Given this list of marker genes KDM5A, LAMC2, EFL1, NOP10, FAM83H, CPLX1, AMBN, TERC, ITGA6, SUMO1, PEPD, P4HB, AMTN, TRMT10A (tRNA methyltransferase 10A), PWRN1, GJA1, WDR35, FGF3, TMEM165, TGFA, WHRN, CDH23, PTCH1, LONP1, ARSB, GNB2, AKT1, AGA, AARS1, IFT43, STX1A, ATRIP, HLA-DRB1, DNAJC21, CHD3, EIF4H, DNA2, IFT122, APC, ZNF469, PGM2L1, UROD, UBR1, SNORD115-1, ZMPSTE24, STIM1, CENPE, CRLF1, DSPP, KRT5, AXIN2, COL1A1, RAD21, DMP1, ERCC8, CLDN16, GTF2IRD1, NUP85, DEAF1, GP1BB, RECQL4, GREM2, SATB1, LRP4, MSX1, SOX9, USH1C, ORAI1, VAC14 (NCBI Gene Id 55697), SLC24A4, ADGRV1, RELT, RTEL1, RUNX2, TARS1, CCDC8, SHOC2, TINF2, LAMB3, IKBKG, GALNS (NCBI Gene Id 2588), ENPP1, SNRPN, GLB1, PLK4, FAM111A, FGFR1, METTL27, PAX9, IL17RA, COL7A1, CCR6, RREB1, PEX6, EDA, ALDH3A2, TRPS1, OFD1, CDH11, RNF113A, ACP4 (NCBI Gene Id 93650), PAX1, NELFA, USH2A, LMX1B, POLR1C, NUP133, JMJD1C, TRIP11, ALPL, USH1G, PKP1, TP63, CLDN1 (claudin 1), GTF2H5, IL17RC, SFRP4, ADNP, ATP6V1A, CARS1, NF1, COL5A1, WRAP53, ATR, ELANE, ZMYM2, SP7, SMARCD2, SCUBE3, IRX5, KIF7, CDH3, TGFB1, WNT10A, POLR1B, FAM20C, TMEM270, FERMT1, RFC2, MEGF8, SLC29A3, ATP6V1E1, HLA-DQB1, TCIRG1, TRPV3, SLC12A2 (NCBI Gene Id 6558), STAT3, SBDS, ASL, ROGDI, OCRL (OCRL inositol polyphosphate-5-phosphatase), GPR68, ANAPC1, CIB2, LAMA3, IFITM5, EDAR, VPS37D, PORCN, GTF2IRD2, KCNJ5, AMELX, SPARC, LRP6, BUD23, NEK1, ALMS1, DPH5, FGFR2, B3GALT6, RBM28, TBCE, P3H1, TERT, CTC1, TNFSF11, BMP1, NECTIN1, GRHL2 (NCBI Gene Id 79977), ABL1, IFT52, SGMS2 (sphingomyelin synthase 2), DLX3, ITGB6, FIG4, FLII, COL17A1, PPP1CB, SEC23A, DHCR7, DNAJC30, LTBP3, MYO7A, ATP6V0A2, PERP, PTCH2, PCGF2, DKC1, IRF5, NHP2, CLIP2, GTF2I, CREBBP, GTF2E2, KLK4, LETM1, NDUFB11, TSC1, SLF2, SNRPB, HERC2, COL1A2, TCOF1, MMP1, KRT14, POLR1D, TRAF3IP2, SLC10A7, ERCC3, LIFR, ARVCF, TRIM37, PGAP1 (post-GPI attachment to proteins inositol deacylase 1), TSC2, PDZD7, SLC19A1, SERPINH1, SERPINF1, COL3A1, PIK3C2A, SLC35A2, TBL2, AIRE, UBE3B, MAPRE2, ERCC6, COX4I2, FKBP6 (FKBP prolyl isomerase family member 6 (inactive)), TRAIP, RAI1 (NCBI Gene Id 6600), NECTIN4, MKRN3, CEP152 (centrosomal protein 152), UFD1, KRAS, PIGG, MMP13, RBBP8, COX7B, PCDH15, FLNA, OBSL1, BAZ1B, EP300, SEC24C (SEC24 homolog C, COPII coat complex component), NTRK1, NPM1, PLEC, PWAR1, TTC7A, KMT2D, PCNT, FAM20A, STX16, MPLKIP, GATA1, CTNND1 (catenin delta 1), GNAS, IQSEC2, PPP1R15B, NCF1, FGF23, SLC37A4, SMCHD1, PAK2, KCNJ2, MMP20, POLD3, UROS, CCN2, WDR19, DIAPH1, SMARCA2, FGFR3, FGF10, CLDN19, COMT, TYMS, RNU12, LIMK1, TBX1, CRTAP, IFNG, CTBP1, ENAM (enamelin), SUFU, HLA-DQA1, ITGB4, PDE4D, PPIB, PHEX, PARN, USB1, FKBP10, THOC6, CDH1, TNFRSF11A, CUL7, TMEM38B, VDR, SEC24D, CTSK, SRCAP, PTDSS1, RAP1B, GALNT3, EDARADD, CYP2R1, ODAPH, BMP4, NPAP1, SLC13A5, MED12, C12orf57, CAV1, FOSL2 (NCBI Gene Id 79579), COL5A2, ERCC1, CLCN7, ESPN, WNT10B, ERCC4, ELMO2, HECTD4, IL17F, CNNM4, FLNB, AP3B1, ERCC2, PEX1, SCNM1, NSD2, ELN, BRF1, WDR72, CYP27B1 (cytochrome P450 family 27 subfamily B member 1), SNORD116-1, IRF6, HCCS, HIRA, PIK3R1, IFIH1, SP6, HRAS (NCBI Gene Id 338029), CSTB, LMNA, MBTPS2, COG6, COL2A1 (collagen type II alpha 1 chain), MIA3, HMBS, CLEC7A, CCDC134, SMOC2, FBXO28, MAGEL2, RHOA, DDX59, NRAS, here is a description of the gene set: Abnormality of dental structure An abnormality of the structure or composition of the teeth. species: Homo sapiens Human Gene Set: HP_ABNORMALITY_OF_DENTAL_STRUCTURE